The following is a description of a gene set: from publication Liberzon A, Birger C, Thorvaldsdóttir H, Ghandi M, Mesirov JP, Tamayo P (PMID 26771021) Human Gene Set: HALLMARK_ALLOGRAFT_REJECTION studied in species Homo sapiens Genes up-regulated during transplant rejection., and this is the list of marker genes: SRGN, MAP3K7, CD86, TGFB1, BCL3, TAP2 (transporter 2, ATP binding cassette subfamily B member), STAT4, CTSS (cathepsin S), CD47, CCL5, CD3D, F2, KRT1, TLR3, CFP, MRPL3 (NCBI Gene Id 11222), ACHE, FCGR2B, WAS, CCND3, HIF1A, IRF7, RPS19, TNF, HLA-DQA1, CCL7, TRAF2, EIF3D, CD1D, HLA-E, PF4, PTPRC, NCF4, GBP2, INHBA, FYB1, LY75, UBE2N, THY1, LY86, RPS3A, LIF, CRTAM, IL7, GZMA, JAK2, HLA-DRA, IL1B, IL2RG, BRCA1, HLA-G, CD8A, CD4, ETS1, DEGS1, CCL13, CD247, TRAT1, CCL4, CCND2, F2R, IFNAR2, CCL11, MTIF2, ABI1, ELF4, LCK, IL12A, CARTPT, NOS2, HLA-DOA, HLA-DMB, IFNG, TIMP1, CD74, STAB1, CD3G, B2M, CCL19, IL10, HLA-DOB, FLNA, WARS1, IRF8, HCLS1 (NCBI Gene Id 3059), TLR6, EGFR, APBB1, CD40, MMP9, IL6, BCL10, DARS1, FASLG (Fas ligand), TPD52, EIF5A, EIF3A, PRF1, CCL2, LCP2, RARS1 (NCBI Gene Id 84715), LTB, CD96, IL2RA, STAT1, IKBKB, NCR1, IFNGR2, EREG, ST8SIA4 (NCBI Gene Id 7903), MBL2, NPM1, C2, EIF3J, AARS1, TLR2, CD7, LYN, SOCS5, DYRK3, NME1, PRKCG, IL12B, GPR65, SIT1, GLMN, CCR1, GCNT1, IL15, EIF4G3, ICAM1, HDAC9, TGFB2, IL2RB, UBE2D1, CCL22, IL4R, CD3E, ITGAL, NLRP3, CD2, IL13, CDKN2A, RPL9, CXCL13, ITGB2, CXCR3, GALNT1, GZMB, AKT1, CXCL9, PSMB10, ABCE1, TAP1, RPL39, INHBB, ZAP70, IL18 (interleukin 18), CD40LG, KLRD1, IL16, CD80 (NCBI Gene Id 941), BCAT1, ELANE, IL4, CD8B, ACVR2A, IL11, TAPBP, PTPN6, RPS9, ITK, CD79A, TLR1, FAS, MAP4K1, IL9, HLA-A, RIPK2, CSF1, CSK, IL2, IFNGR1, IRF4, CCR5, CAPG, SPI1, FGR, IL27RA, RPL3L, IL18RAP, IGSF6, HLA-DMA, CCR2, CD28, NCK1, ICOSLG, IL12RB1, SOCS1, PRKCB (protein kinase C beta)